Given this list of marker genes EVI5L, CEP97, TESK1, TCHP (trichoplein keratin filament binding), YAP1, GDI2, LPAR1, KIF24, LIMK2, TBC1D7, CDK10, MAK, MPHOSPH9, AKT1 (NCBI Gene Id 207), MAP4, TRIM32, LIMA1, LUZP1, CCP110 (NCBI Gene Id 9738), MARCHF7, ODF2L, WDR44, TBC1D30, here is a description of the gene set: species: Homo sapiens Any process that stops, prevents or reduces the frequency, rate or extent of cilium assembly. Human Gene Set: GOBP_NEGATIVE_REGULATION_OF_CILIUM_ASSEMBLY